The following is a description of a gene set: Any of several protein complexes required for the biogenesis of specialized organelles of the endosomal-lysosomal system, such as melanosomes, platelet dense granules, and other related organelles; acronym for biogenesis of lysosomal-related organelles complex. studied in species Homo sapiens Human Gene Set: GOCC_BLOC_COMPLEX, and this is the list of marker genes: BLOC1S3, SNAP25, BLOC1S5, WASHC4, BLOC1S4, BLOC1S1, BLOC1S6 (NCBI Gene Id 26258), HPS4, KXD1, STX12, BCAS4, HPS6, HPS1, HPS5, DTNBP1, SNAPIN, PI4K2A, SNAP47, HPS3, BLOC1S2